The following is a description of a gene set: The process in which a post-anal tail is generated and organized. A post-anal tail is a muscular region of the body that extends posterior to the anus. The post-anal tail may aid locomotion and balance. Mouse Gene Set: GOBP_POST_ANAL_TAIL_MORPHOGENESIS species: Mus musculus, and this is the list of marker genes: Scrib, Med12, Chst11, Dchs1, Hes7, Fgf3, Fgfr3, Trp63, Epha2, Lrp6, Ripply2, Prickle1 (prickle planar cell polarity protein 1), Tmed2, T, Vangl2, Palb2, Sfrp2, Akp3, Wnt5a, Traf3ip1, Sfrp5, Wnt3a, Tcf15, Axin1, Npr2, Fzd3, Sp5, Hottip, Hotair